Given this list of marker genes RALGDS, SOS1, EGFR, HRAS, RALA, SOS2, NRAS, EGF, GRB2, RALB, KRAS, here is a description of the gene set: studied in species Homo sapiens Human Gene Set: KEGG_MEDICUS_REFERENCE_EGF_EGFR_RAS_RALGDS_SIGNALING_PATHWAY EGF-EGFR-RAS-RalGDS signaling pathway. Pathway ID: N00103. Pathway type: Reference. Pathway class: nt06260 Colorectal cancer. Pathway Definition from KEGG: EGF -> EGFR -> GRB2 -> SOS -> RAS -> RALGDS -> RAL